Given this list of marker genes Dmtn, Itgb1bp1, Ogt, Usp17le, Gdi1, Kcne1, Inpp5k, here is a description of the gene set: Mouse Gene Set: GOBP_NEGATIVE_REGULATION_OF_PROTEIN_TARGETING_TO_MEMBRANE Any process that decreases the frequency, rate or extent of the process of directing proteins towards a membrane, usually using signals contained within the protein. studied in species Mus musculus